Given this list of marker genes CACNA1B, VDAC2, CACNA1F, CASP7, CACNA1H, CACNA1G, SLC25A6 (NCBI Gene Id 8283), SLC25A5, CACNA1C, CACNA1D, VDAC1, MCU, SLC25A31, CASP3, CACNA1I, CACNA1A, CYCS, CASP9, CACNA1E, VDAC3, CACNA1S, SLC25A4, APAF1, here is a description of the gene set: Pathway Definition from KEGG: Ca2+(extracellular) -- VGCC -> Ca2+ -- MCU -> Ca2+(mito) -- MPTP -> CYCS == APAF1 -> CASP9 -> (CASP3,CASP7) VGCC-Ca2+ -apoptotic pathway. Pathway ID: N00967. Pathway type: Reference. Pathway class: nt06460 Alzheimer disease. studied in species Homo sapiens Human Gene Set: KEGG_MEDICUS_REFERENCE_VGCC_CA2_APOPTOTIC_PATHWAY